Given this list of marker genes NUDT22 (nudix hydrolase 22), SIRPB1, ORC5, ASIC3, BST2, SLC39A5, C17orf100, FPR2, TPST1, SMC1B, RNASET2, CYBB, RPN2, ULK4, KCNMA1, PGAP3, CD38, MPV17L2, NDUFS3, COMMD1, C1orf54, FCGR2B, PMCH, NDUFV3 (NADH:ubiquinone oxidoreductase subunit V3), TXLNB, SLC25A6, SDHD, CXCR2, LRFN2, IFI35, SLFN12, SDHB, AQP12A, HK3, SPACA3, ADAMTS16, BSG, ITGAM, GGT1, GPI, TMEM89, PILRA, APMAP, ATP1A2, LIAT1 (NCBI Gene Id 400566), ERAP1, PSME2, ATP13A5, ABHD11, TAPBPL, STRA8, IGFBP2, DLGAP1, CFAP206, SAMD5, POU3F2, HP, KCNAB2, RASGRP1, RAC2, PKM, CST7, CANX, AMH, CSDE1, MMP14, ARK2C, VTI1A, MARCO, NXPE3, SPATA46, CAMKK1, RGS9, DACH1, IL21R, PDCD1LG2, NUDT19, CHCHD7, B2M, TAP2, P2RY14, WBP2NL, NODAL, OVOL1 (ovo like transcriptional repressor 1), CACNG2, SPTLC3, MISP, KCNC1, LRRC40, TFAP2D, HAGH, ZBBX, TSPO2, SEMA6C, VPS26B, TRPM2, ARHGDIB, BMERB1, XAF1, FBXL20, FNDC8, IFT140, C3, KIF26A, LARGE2, DNER, PRSS21, TMBIM6, PRDX2, STXBP3, OASL, IL2RG, HCK, ASS1, SOX18, VNN2, ENO1, KLHL11, STT3A, TSPO, GNB1, SNX20, UBAC2, SPIDR, TNNT1, DRP2, SIGLEC7, CFB, ALDOA, GSDMD, ST8SIA2, SLC25A35, SOD2, ATP5PO, CLYBL, PSORS1C2, ATP10D, PRRT4, CFAP298, MIXL1, ZNHIT1 (zinc finger HIT-type containing 1), UNC13D, MUC13, APP, MRPS16, ACP5, FOXRED2, GLI2, UBE2L6, RIPK3, PSME1, ASPHD2, COX6B1, MRPL27, DNM1 (dynamin 1), HRG (NCBI Gene Id 3273), IL15RA, CCKBR, NFIC, PSMB8, VSTM2B, SLC5A11, PNP, HLA-DRA, MYD88, HLA-B, TAP1, USP3 (ubiquitin specific peptidase 3), PTPRCAP, AOAH (acyloxyacyl hydrolase), SNHG6 (NCBI Gene Id 641638), FCER1G (NCBI Gene Id 2207), DHRS1, ATXN7L1, FKBP2, TP63, CCL24, HSD3B2, PRDX5, FSD1, OAS1, DEF8, MYRF, PSMB10, RAB3D, CHST12, IL17RD, PI4K2A, C1R, NR5A1 (NCBI Gene Id 2516), TBL1XR1, AGTRAP, SEMA4A, GDPD3, TMC8, USP18, STAT1, PRLR, CRACD, FKBP6, here is a description of the gene set: studied in species Homo sapiens Human Gene Set: GSE46606_IRF4HIGH_VS_WT_CD40L_IL2_IL5_DAY3_STIMULATED_BCELL_DN Genes down-regulated in CD40L and IL-2 IL-4 IL-5 stimulated at day 3 B cell IRF4high versus CD40L and IL-2 IL-4 IL-5 stimulated at day 3 B cell wildtype. from publication Ochiai K, Maienschein-Cline M, Simonetti G, Chen J, Rosenthal R, Brink R, Chong AS, Klein U, Dinner AR, Singh H, Sciammas R (PMID 23684984) Temporal analysis of B cell activation in vitro using CD40L and IL-2/4/5 cytokines in wild type Irf4+/+ B cells or in mutant Irf4-/- B cells harboring a tet-inducible allele of Irf4. IRF4 expression was restored, or not, in the Irf4-/- background by culturing in the presence of low or high concentrations of doxycycline. The results provide insight in the role of IRF4 expression levels in coordinating different programs of B cell differentiation.